The following is a description of a gene set: studied in species Homo sapiens part of: Fructose metabolism Reactome Pathway: Fructose catabolism Fructose occurs naturally in foods as a free monosaccharide and as a component of the disaccharide sucrose. It is also widely used as a sweetener. In the body, fructose catabolism occurs in the liver and to a lesser extent in the kidney and small intestine. In these tissues, it is converted to dihydroxyacetone phosphate and D-glyceraldehyde 3-phosphate, two intermediates in the glycolytic pathway, in a sequence of three reactions. It is phosphorylated to form fructose 1-phosphate, which is cleaved by aldolase to yield dihydroxyacetone phosphate and D-glyceraldehyde, and the latter compound is phosphorylated to yield D-glyceraldehyde 3-phosphate. Other pathways exist for the conversion of D-glyceraldehyde to intermediates of glycolysis, but these appear to play only a minor role in normal fructose metabolism., and this is the list of marker genes: ALDH1A1, TKFC, GLYCTK, ALDOB, KHK